Given this list of marker genes PLOD1, CSF1 (colony stimulating factor 1), PRKAR2B, ENC1, PEPD, EMC8, NAA60, ALOX15, SLC31A2, VAC14, SEL1L, CPD, ERCC1, ARHGEF10L, SLC30A1, BLVRA, COLEC12, ATP6V0D1, MAPK1, HADH, DDX31, RAB5IF, CHST11, FAM162A (NCBI Gene Id 26355), NDRG2, REXO5, CTNNA1, CXCR2, TGFBI, H2AC6, RER1, PPP1R26, PLCG2, TENT5A, FES, WNT5B, TOR3A, AIMP2, ABCC3, CTSD, FOSL1, CELSR1, CTSZ, CCL17 (C-C motif chemokine ligand 17), ACOX1, TNFRSF21, BCKDK, SYT17, SUOX, FABP5 (fatty acid binding protein 5), ACOT7, NACC2, CYBB, SPARC, PFKP, PTGS1, DHCR24, LAMP1, ATP6V1D, CDA, RAB38, FARP1, ANPEP, NTAQ1, RASGRP3, PRDX3, MRAS, BST1, PYGL, CCNH, PCOLCE2, PDGFA, SPRY2, CDC42BPB, FN1, RAMP1, TLR7, SLC2A8, NUMB, FCER1A, SLAMF8, SLC25A44, VPS41, MYOF, MATK, IGSF6 (NCBI Gene Id 10261), TMEM9B, NR4A3, HSD3B1, RUFY1, FUCA1, RIPK4 (receptor interacting serine/threonine kinase 4), LILRA2, ATP6V0B, FXYD6, ANXA11, TACSTD2, CTTN, MIR22HG, ADCK2, GPNMB, PIR, CAPG, FEN1, ALDH1A1, CARD9, TBC1D2, FBP1, CYB5R1, KYNU, SORT1, PDGFC, FTH1, TBC1D16, HLA-DRA, HK3, TM6SF1, LPAR1, ACO2, FLT1, MRC2, PTRH2, CD36, WBP4, DNPEP, BTK, GRN, CD1E, CENPN, TPP1, RALB, ARMCX1, ABCG2, PECAM1, CTSC, CD83, GGCT, FDX1, CD9, HSBP1, AGPAT4, STX3, P4HA1, NSDHL, STXBP1, SLC48A1, CKAP4, TXNRD1, CASP5, CPT2, FCGR2B, PSMA2, ABHD6, TALDO1, TFE3, DCSTAMP, SDC4, PPARG, NPL, PLXNB2, RAB31, MKLN1, KMO, MS4A6A, VCL, MCUR1, ORC1, WDR12, VDR, CDCP1 (NCBI Gene Id 64866), LGALS1, FCGR2C, HSD17B4, SLC15A3, CD1B, SLC47A1, FHOD1, HSD11B1, PRCP, UTP6, IRF8, NANS, C5AR1, SNX5, CD33, UGP2, NPC1, NFKBIE, CDKN1A, SDC2, MMP9, NFIL3, FGR, CTSH, BASP1, MAOA, CD1C, KCNJ1, CFD, PLA2G4C, here is a description of the gene set: from publication Jeffrey KL, Brummer T, Rolph MS, Liu SM, Callejas NA, Grumont RJ, Gillieron C, Mackay F, Grey S, Camps M, Rommel C, Gerondakis SD, Mackay CR (PMID 16474395) Human Gene Set: GSE3982_DC_VS_CENT_MEMORY_CD4_TCELL_UP In the present study we used Affymetrix oligonucleotide microarrays to produce gene transcription profiles for the major leukocyte types in humans. This comprehensive dataset enabled us to not only establish which genes were expressed in each leukocyte type, but also which genes were expressed in each subset after activation. The used of a comprehensive dataset of gene profiles from all the major human leukocyte subsets enabled a novel and powerful means for identification of genes associated with single leukocyte subsets, or different immune paradigms. species: Homo sapiens Genes up-regulated in comparison of dendritic cells (DC) versus central memory CD4 T cells.